The following is a description of a gene set: part of: Interleukin-1 family signaling Reactome Pathway: Interleukin-1 signaling species: Homo sapiens Interleukin 1 (IL1) signals via Interleukin 1 receptor 1 (IL1R1), the only signaling-capable IL1 receptor. This is a single chain type 1 transmembrane protein comprising an extracellular ligand binding domain and an intracellular region called the Toll/Interleukin-1 receptor (TIR) domain that is structurally conserved and shared by other members of the two families of receptors. This domain is also shared by the downstream adapter molecule MyD88. IL1 binding to IL1R1 leads to the recruitment of a second receptor chain termed the IL1 receptor accessory protein (IL1RAP or IL1RAcP) enabling the formation of a high-affinity ligand-receptor complex that is capable of signal transduction. Intracellular signaling is initiated by the recruitment of MyD88 to the IL-1R1/IL1RAP complex. IL1RAP is only recruited to IL1R1 when IL1 is present; it is believed that a TIR domain signaling complex is formed between the receptor and the adapter TIR domains. The recruitment of MyD88 leads to the recruitment of Interleukin-1 receptor-associated kinase (IRAK)-1 and -4, probably via their death domains. IRAK4 then activates IRAK1, allowing IRAK1 to autophosphorylate. Both IRAK1 and IRAK4 then dissociate from MyD88 which remains stably complexed with IL-1R1 and IL1RAP. They in turn interact with Tumor Necrosis Factor Receptor (TNFR)-Associated Factor 6 (TRAF6), which is an E3 ubiquitin ligase. TRAF6 is then thought to auto-ubiquinate, attaching K63-polyubiquitin to itself with the assistance of the E2 conjugating complex Ubc13/Uev1a. K63-pUb-TRAF6 recruits Transforming Growth Factor (TGF) beta-activated protein kinase 1 (TAK1) in a complex with TAK1-binding protein 2 (TAB2) and TAB3, which both contain nuclear zinc finger motifs that interact with K63-polyubiquitin chains. This activates TAK1, which then activates inhibitor of NF-kappaB (IkappaB) kinase 2 (IKK2 or IKKB) within the IKK complex, the kinase responsible for phosphorylation of IkappaB. The IKK complex also contains the scaffold protein NF-kappa B essential modulator (NEMO). TAK1 also couples to the upstream kinases for p38 and c-jun N-terminal kinase (JNK). IRAK1 undergoes K63-linked polyubiquination; Pellino E3 ligases are important in this process.. The activity of these proteins is greatly enhanced by IRAK phosphorylation, leading to K63-linked polyubiquitination of IRAK1. This recruits NEMO to IRAK1, with NEMO binding to polyubiquitin.<br><br>TAK1 activates IKKB (and IKK), resulting in phosphorylation of the inhibitory IkB proteins and enabling translocation of NFkB to the nucleus; IKKB also phosphorylates NFkB p105, leading to its degradation and the subsequent release of active TPL2 that triggers the extracellular-signal regulated kinase (ERK)1/2 MAPK cascade. TAK1 can also trigger the p38 and JNK MAPK pathways via activating the upstream MKKs3, 4 and 6. The MAPK pathways activate a number of downstream kinases and transcription factors that co-operate with NFkB to induce the expression of a range of TLR/IL-1R-responsive genes. There are reports suggesting that IL1 stimulation increases nuclear localization of IRAK1 and that nuclear IRAK1 binds to the promoter of NFkB-regulated gene and IkBa, enhancing binding of the NFkB p65 subunit to NFkB responsive elements within the IkBa promoter. IRAK1 is required for IL1-induced Ser-10 phosphorylation of histone H3 in vivo. However, details of this aspect of IRAK1 signaling mechanisms remain unclear. Interleukin-18 is another Interleukin-1 related cytokine which signals through IL18R and IL18RAP subunit receptors (which share homology with IL1R and IL1RAP in the cytokine signaling cascade). Later it follows a MYD88/IRAK1/TRAF6 cascade signaling until reach the NFKB activation. Interleukin 33, 36, 37 and 38 are relatively recently discovered Interleukin-1 related citokines which are also able to signal through IL1 receptor subunits or other as IL18R, IL37R., and this is the list of marker genes: MAP3K3, PSMD2, NLRX1, PSMC1, FBXW11, PSMA1, RBX1, PSMD8, UBE2V1, MAP3K8, TRAF6, HMGB1, PSMD14, PSMC4, MAP2K6, PSMA7, NOD2, MYD88, RPS27A, PSMB5, PELI2, NOD1, PSMD7, PSMA2, PSMB4, NFKB1, PSMC2, NKIRAS1, AGER, NFKBIA, IL1RAP, TAB1, PSMB3, PSMD6, PSMD11, IKBKG, UBA52, BTRC, SQSTM1 (sequestosome 1), N4BP1, RIPK2, ALPK1, RELA, PSMC5, TIFA, PSMA3, IL1A, MAP2K4, TRAF2, TAB2, PSMA6, PSMD1, MAP2K1, UBE2N, PSMC6, IRAK4, SKP1, ADRM1, IL1RN, TP53, PSMB7, IL1R2, PSMB1, NFKB2, IKBKB, TNIP2, IL1R1, TOLLIP, IRAK3, CUL1, IL1B, PSMA4, SAA1, IKBIP, PSMC3, PSMD3, USP18, NKIRAS2, TAB3, PSMA5, MAP3K7, IRAK1, S100A12, PELI1, PELI3, UBC, NLRC5, SEM1, NFKBIB, USP14, LRRC14, N, PSMB2, CHUK, UBB, PSMB6, IRAK2, PSMD12, CASP8, S100B, APP, PSMD13